The following is a description of a gene set: species: Homo sapiens Human Gene Set: GOBP_REGULATION_OF_CILIUM_DEPENDENT_CELL_MOTILITY Any process that modulates the frequency, rate or extent of cilium-dependent cell motility., and this is the list of marker genes: TEX101, CFAP20, CFAP206, PGAM4, TAC4, BBS1, EPPIN, CFAP69, BBS4, ADAM7, PRDM14, CLXN, GAS2L2, KIF9, TAC1, IRGC, SEMG1, SEMG2, CATSPER1, MKKS, TTLL6, TACR1, TACR2, TPPP2, TAC3, CFAP45, BBS2, CCR6, RNASE10, DEFB1, TACR3, IQCF1